The following is a description of a gene set: part of: Metabolism of carbohydrates and carbohydrate derivatives Reactome Pathway: Fructose metabolism species: Homo sapiens Fructose is found in fruits, is one of the components of the disaccharide sucrose, and is a widely used sweetener in processed foods. Dietary fructose is catabolized in the liver via fructose 1-phosphate to yield dihydroxyacetone phosphate and glyceraldehyde 3-phosphate, which then are converted to pyruvate via steps of canonical glycolysis (Hers & Kusaka 1953; Sillero et al. 1969). Excessive dietary intake of fructose and its metabolism have been associated with major disease risks in humans, although this issue remains controversial (Kolderup & Svihus 2015; DiNicolantonio et al. 2015; Bray 2013; Mayes 1993; Rippe & Angelopoulos 2013; van Buul et al. 2013). Fructose can also be synthesized from glucose via the polyol pathway. This synthetic process provides the fructose found in seminal fluid and, in other tissues, can contribute to pathologies of diabetes., and this is the list of marker genes: SORD, ALDOB, KHK, GLYCTK, AKR1B1, ALDH1A1, TKFC